Given this list of marker genes Inpp5e, Mydgf, Them4, Lime1, Cntnap2, Ccl21f, Pik3ca, Pik3cb, Pdgfb, Sfrp5, Ccl21a, Ncor1, Sesn2, Ngf, Pkhd1, Ppp2r1a, Lep, Itgb1, Sco1, Cryba1, Kdr, Tgfb1, Xbp1, Htr2a, C1qbp, Twist1 (NCBI Gene Id 22160), Tgfbr1, Egf, F2rl1, Pdpk1 (3-phosphoinositide dependent protein kinase 1, NCBI Gene Id 18607), Ntrk1, Reln, Osbpl8 (NCBI Gene Id 319994), Drd2, Flt1, Irs1, P2ry12, Ngfr, Chi3l1 (NCBI Gene Id 98675), Hdac2, Erfe, Pnma5, F2r, Ccl19-ps6, Gdf15, Fshr (follicle stimulating hormone receptor), Wnt16, Fyn, Hax1, Adora3, Dab2ip, C1qtnf1, Cxcl12, Pdgfrb, Prex2, Mfhas1, Magi2 (NCBI Gene Id 50791), Ramp3, Tgfb2, Gpx1, Rasgrp1, Mtm1, Pik3c2b, Pik3r4, Gab2, Fbxl2, Ddit3, Extl3, Mup4, Lin28a, Blvra, Stat3, Mertk, Nkx3-1, Pde3b, Fkrp, Errfi1, Cavin3, Cd160, Vegfa, Sesn1, Ntrk2, Wdr91, Hnf1a, Phlda3, Thpo, Meis3, Htr2b, Tek, Nedd4, Ceacam1, Pik3r1, Rnf41, Cdc42, Cd40, Fam110c, Dipk2a, Pdgfa, Nyap1, Pld2, Sirt7, Fer, Erbb2, Ccl19-ps1, Rac1, Mst1r, Ins1, Specc1l, Ceacam2, Gfral, Fgr, Mtdh, Gata3, Inpp5f (NCBI Gene Id 79372), Sema4d, Park7, Cx3cr1, Prkca, Ambra1, Igfbp5 (insulin-like growth factor binding protein 5), Igf1r (NCBI Gene Id 77773), Mmp3, Axl, Hbegf, Pros1, Pdgfd, Ppp1r16b, Akt1, Vav1, Atg14, Rubcn, Vegfb, Flcn, Ntrk3, Bag4, Fam3c, Cd19, Stox1, Abcc2, Src, Nox4, Nf1, Ppp2ca, C1qtnf3, Stk11, Txn1, Csf3, Adam8, Cpne1, Rcn3, Fgfr3, Cib1, Aim2, Btn2a2, Kbtbd2, Arfgef1, Smpd3, Selp, Fn1, Sesn3, Ddr1, Usp49, Nop53, Ptpn13, Akr1c18, BC028528, Rapgef1, Ccl19-ps5, Stambp, Sema3e, Ltk, Klf4, Insr, Agt, Rictor (NCBI Gene Id 78757), Ccl21e, Ube3a, Cx3cl1, Nrxn1, Gcnt2, Ccl5, Phb1, Otud3, Ptk2, Gsk3b, Dlg1, Xdh, Pik3c3, Gas6, Myorg, Prr5, Calcr, Drd3, Serpine2, Nrg1, Akt2, Klk1b4, Il6, Osm, Edn1, Inppl1, Rgl2, Pik3r2, Ccl19-ps3, Pik3cg, Cd2ap, Cav3, Mup11, Itsn1, Pdcd6, Mup2, Ryk, Lox, Plxnb1, Agap2 (ArfGAP with GTPase domain, ankyrin repeat and PH domain 2), Col6a1, Ret, Grm2, Crnn, Ptpn6, Hpse, Pik3ip1, Arrb2, Hgf, Ccl21b, Pik3c2g, Unc5b, Ccl21d, Tyro3 (TYRO3 protein tyrosine kinase 3, NCBI Gene Id 98916), Hyal2, F2, Lemd2, Trem2, Nts, Pik3cd, Mup3, C1qtnf12, Tnf, Col6a2, Tcf7l2, Atp1a3, Thbs1, Irs3, Rapgef3, Serpina12, Ins2, Tspyl5 (NCBI Gene Id 239364), Cd28, Mkrn2, Eng, Pik3c2a, Wdr72 (NCBI Gene Id 639441), Ccl19-ps4, Prr5l, Nherf1, Angpt1, Lingo1, Prkd1, Pik3ap1, Cass4, Cep55, Irs2, Zfp36l1, Egfr, Epha8, Ptprj, Ilk, Myoc, Fermt2, Col6a3, Ppard, Cntf, Plk3, Sh2b3, Igf1, Mup1, Inpp5k, Mstn, Rasd2, Bank1, Cdkn2a, Cbl, Stk3, Nyap2 (NCBI Gene Id 241134), Ppara, Hcst, Pdgfra, Gper1, Ccdc88a, Pik3r3, Clcf1, Obscn, Nherf2, Jak2, Ndp, Iapp, Ift80, Tnfsf11, Fgf2, Epha7, Lrp2, Btbd10, Itgb1bp1 (NCBI Gene Id 16413), Tpbg, Reg1 (NCBI Gene Id 19692), H2-M3, Tmem100, Spry2, Mir423, Erbb4 (erb-b2 receptor tyrosine kinase 4), Il18, Ptpn1, Plekha1, Ptk2b, Sema5a, Mir494, P2rx4, Dcn, Ddr2, Mup5, Rras, Pdgfc, Fgfr1, Hmga1, Pear1, Rack1, Phlpp1 (PH domain and leucine rich repeat protein phosphatase 1), Hcls1, Ulk4, Inpp4b, Myo16, Pik3r5, Dag1, Cat, Nlrc3, Ccl19, Mul1, Mir143, Sirt1, Tsc2, Pten, Rtn4, Erbb3, Mtor, Csf1r, Vav2, Mir205, Igf2, Maz, Vav3, here is a description of the gene set: Mouse Gene Set: GOBP_PHOSPHATIDYLINOSITOL_3_KINASE_PROTEIN_KINASE_B_SIGNAL_TRANSDUCTION studied in species Mus musculus An intracellular signaling cassette that starts with phosphatidylinositol 3-kinase (PI3K) activation, production of phosphatidylinositol 3-phosphate (PI3P), activation of PDK1, which recruits and ending with the activation of protein kinase B (PKB, also known as Akt). PI3K is activated by cell surface receptors. Note that PTEN is an inhibitor of the pathway.